The following is a description of a gene set: Any process that activates or increases the frequency, rate or extent of protein complex assembly. studied in species Homo sapiens Human Gene Set: GOBP_POSITIVE_REGULATION_OF_PROTEIN_CONTAINING_COMPLEX_ASSEMBLY, and this is the list of marker genes: CCL26, PRKD1, CLASP1, SYK, TP53, BAX, MSN, MARCHF5, MPP7, TNF, PSRC1, BAIAP2, DDX3X, FSCN1, CCL24, STMP1, BBC3, WASHC2C, ALOX15, SNCA, BCL2L11, NR1H2, SH3GLB1, TGFB1, SNX9, MECP2 (NCBI Gene Id 8274), LMOD1, TLR6, TENM1, EVL, FES, ISG15, CDC42EP3, DHX33, MTOR, CCL11, UNC13B, CKAP5 (NCBI Gene Id 9793), NCK2, CCL21, RAP1B, DCTN1, BAK1, KCNK6, NPHS1, ZDHHC5, RHOA, HSP90AA1, MAPRE1, VCP, MAPK8, P2RX7, CAPG, SLF1, FERMT1, PFN2, FNIP2, CDH5, OCLN, EIF4G1, LATS1 (NCBI Gene Id 9113), TAL1, CARMIL1, DRG1, CREB1, SLAIN2, BIK, PLCG2, ARHGEF5, WARS1, CARMIL2, SLF2 (NCBI Gene Id 55719), CDC42EP5, PRKCE, IL5, TPPP3 (NCBI Gene Id 51673), FNIP1 (NCBI Gene Id 96459), RICTOR, CDC42EP4, ARF6, C15orf62, PFN1, GNL3L, GBP2, HIP1R, MTLN, BMF, BRCC3, MYD88, TTBK1, BAIAP2L1, CLEC7A, ARPC2, CDK5R1, NCKAP1, ABCA3, MAPT, DAB2IP (DAB2 interacting protein), NCKAP1L, GIT1, MAP1B, PAK1, BIN1, ANKRD53, PYCARD, PINK1, PPP2R5B, MLST8, LMOD2, PARK7, CDC42EP1 (NCBI Gene Id 129136), LCP1, ICE1, ATAT1, SRC, PPP2CA, GRB2, HSPA1B (NCBI Gene Id 3304), DLG1, RACK1, TOGARAM1, SLAIN1, CXCL13, CDK5RAP2, HCK, NUMA1, TLR4, PTPN22, NRG1, AKAP9, CLIP1, MMP1, BTK, TERF1, P2RY12, NAV3, CSF3, MARK4, LGALS3, PDE4DIP, BRK1, RASIP1, TRABD2A, CRBN, SKAP1, TPPP, CCR7, STUB1, KIRREL1, ZDHHC1, NCK1, SUMO1, TRABD2B, ARL2, WNT10B, FCHSD1, SPIDR, FCHSD2, BID, PLEK, MMP3, TIRAP, BAG4, MAVS, PIEZO1, CSF2, AMBRA1, GBP5, PSMC6, TFRC, HSPA1A, LATS2, HDAC6, RPS3, TPPP2, CDC42EP2, GSK3B, VASP, TRIM65, CDKN1B, CD36, NEK7, IFNG, AJUBA, PTK2B (protein tyrosine kinase 2 beta), RHOC, HRK, MAPK9, CAND1, CAV3, USP50, CRACD, CDH17, RAC1, VEGFA, BAIAP2L2, FERMT2 (FERM domain containing kindlin 2), ABCA1, SKA1, ATR, ATM, MED25, MET, CTTN, CLU, FER